Given this list of marker genes TICAM1, FXYD2, KCNQ1, SLC12A1, SCNN1G, TERT, SEC61A1, NR0B1, PIEZO1, GCSH, GATM, TP53, TRAF3, NDUFB8, SYK, CALM1, PLVAP, EHHADH, CACNA1D, SLC4A2, SCNN1A, ARNT2, SERPINA6, SETD2, NDUFAF6, KCNJ5, SCN4B, SLC5A1, IL36RN, GEMIN4, CPOX, ANK2, AQP2, KCNE1, ELP1, SCN5A, HSD3B2, AKAP9, COL3A1, ALG8, POLG2, LPIN1, KCNE3, SLC34A1, CDH23, INSR, CLCNKB, ATIC, CASR, NOS1AP (nitric oxide synthase 1 adaptor protein), KCNJ18, CACNA1S, KCNN4, PPOX, AVPR2, OCRL, OBSCN, SLC4A4, PAX2, MT-CO3, CA12, KCNH2, CLCN2, KCNJ1, WNK4, TBX5, SARS2, NR3C1, SLC12A3 (solute carrier family 12 member 3), IRF4, MT-CO1, CLCNKA, NR3C2, RYR1, SCN4A, AIP, ATP6V0A4, KCNE2, CRELD1, TXNRD2, BSND, CUL3, KCNJ2, ATP1A1, HMBS, SLC2A1, PRF1, SAMD9 (NCBI Gene Id 54809), ALG12, TBX19, BMPR1A, PBX1, TLR3, CDKN2A, CYP11A1, ALAD, NNT, WNK1, HSD11B2, CA5A, EIF2AK3, RRAGD, CACNA1C, CALM2, POR, MC2R, NFKB2, STAR, KLHL3, PRKAR1A, SLC9A3, INVS, SCNN1B, PKHD1, USP8, PKD2, SLC2A2, FOCAD, ASL, FGFR1, UNC93B1, SNTA1, CALM3, ZNRF3, CYP11B2, CYP11B1, AP1S3, KCNJ10, TDP2, ABCB6, CTNNB1, TBK1, DSG1, NUP214, CTNS, LYST (NCBI Gene Id 1130), DEF6, UNC45A, CLDN10, DZIP1L, SMAD4, MRAP, MAGED2, TRDN (triadin), SLC30A9, CYP17A1, ALDOA, GABRA3, TSFM (Ts translation elongation factor, mitochondrial), SLC4A1, SCN10A, SLC26A3, CAV3, here is a description of the gene set: Abnormal blood monovalent inorganic cation concentration An abnormality of monovalent inorganic cation homeostasis. species: Homo sapiens Human Gene Set: HP_ABNORMAL_BLOOD_MONOVALENT_INORGANIC_CATION_CONCENTRATION